Given this list of marker genes HHATL (NCBI Gene Id 57467), ITGB3, APOD, ITGAV, DBI, here is a description of the gene set: studied in species Homo sapiens Human Gene Set: GOBP_NEGATIVE_REGULATION_OF_LIPOPROTEIN_METABOLIC_PROCESS Any process that stops, prevents, or reduces the frequency, rate or extent of the chemical reactions and pathways involving lipoproteins, any conjugated, water-soluble protein in which the nonprotein group consists of a lipid or lipids.